The following is a description of a gene set: studied in species Homo sapiens Human Gene Set: GOBP_DE_NOVO_PROTEIN_FOLDING The process of assisting in the folding of a nascent peptide chain into its correct tertiary structure., and this is the list of marker genes: ENTPD5, DNAJB5, HSPA1B, DNAJB1, TOR1A, HSPA6, FKBP1A, DNAJB13, ERO1A, HSPA7, HSPA13, HSPA14, ST13 (ST13 Hsp70 interacting protein), HSPA9, TELO2, PTGES3, DNAJB4, HSPA1L, HSPH1, DNAJC7, DNAJC2, SELENOF, HSPD1, HSPA5, DNAJB14, HSPE1, UGGT1, SH3GLB1, FKBP1B, HSPA8, CD74, DNAJC18, TOR2A, TOR1B, BAG1, HSPA2 (NCBI Gene Id 3306), HSPA1A, DNAJB12